The following is a description of a gene set: Genes predicted to be targets of miRBase v22 microRNA hsa-miR-4477a in miRDB v6.0 with MirTarget v4 prediction scores > 80 (high confidence targets). studied in species Homo sapiens Human Gene Set: MIR4477A from publication Chen Y, Wang X (PMID 31504780), and this is the list of marker genes: GHR, TBXAS1, MOXD1, DIP2A, TUBB3, TENT4A, KIF11, ZCWPW1, SLC4A10, SLAIN2, WASHC4, LRRC8D, LRCH2, CD274 (CD274 molecule), PPP2R2A, SLC22A15, RAP1GDS1 (NCBI Gene Id 5910), TBC1D9B, NUFIP2, ARID4A, IL2, LGALS3, MBNL3, SMAP2, PF4V1, GNGT1, PTPN4, USP47, PRICKLE1, JPH1, NR0B1, RAB21, KLHL17, SON, PASD1, TWSG1, ISL2, E2F5, LIN7C, NALF1, TMEM108, VTA1, PDE7B, CAVIN2 (caveolae associated protein 2), CTSS (NCBI Gene Id 50653), ATP8A1, FAM200C, U2AF1L4, SSR3, HMGN5, ORC6, USP25, SCAI, CNRIP1, EIF3J, SLC17A6, F2R, CNTNAP2, UBR3, NAP1L1, MKLN1, ERRFI1, PPM1E, KLHL1, UGT8, GFM1, SORBS1, MYCT1, PCOLCE2, PAGE2, RBM26, UTP18, TCEAL7, CASK, ARHGAP45, UHRF2 (NCBI Gene Id 49857), RWDD4, SLC25A24, NRXN1, ZDHHC9, ST8SIA4, KRTAP9-9, MAP4K5, RAP2C, USP43, ZCRB1, LRATD2, STIL, FZD3, OSBPL3, PTPRK, TNPO1, DNAJC25, ZDHHC13, TAF3, JAG1, KLF3, RWDD1, CLTRN, SHISA2, ENY2, MRFAP1, DLAT, SETBP1, KLF15, BLTP3B, SC5D, FBXW11, BRI3BP, C14orf132, PAMR1, MMP16, MACC1, PARG, HESX1, EYA1, ING3, MINDY2, RECK, CKAP4, GFI1, PTPRB, C5orf24, SIGLEC10, RNF213, ACKR3, ZNF280C, SLC35A4, UXS1, HOXA13, ABHD4 (NCBI Gene Id 63874), KRTAP1-5, DGKH, BRWD3, MAGEC2, RASA2, RPRM, MTHFD2, RBMX, ALDH1A1, RC3H1, UBR1, PCDHB5, KLRF1, FGFR2, RSF1, RSPO4, CACNB4, KCND2 (potassium voltage-gated channel subfamily D member 2), TENT2, SYPL1, KLHL32, IER5L, CDK15, CUX2, OXNAD1, SLC18A2, MCTS1, PTPN11, TKTL1, MPP7, ARHGEF12, TAB2, MIER3, MS4A12, TSLP, TNKS2, ACADL, TFRC, RIPOR2, GEM, GK5, TM9SF2 (transmembrane 9 superfamily member 2), UBL5, ANK1, DIPK2A, POLR2D, SDHAF3, DNAJB4, RNF138, CCP110, CEP76, HNRNPD, DHFR2, PDE11A, TPRA1, PCLO, INHBE, CDH20, CFAP95, GSPT1, ASCC3, SSPN, PKD2, AMOTL2, RNF146, SLC46A3, ENTPD1, ANAPC5, CNOT7, KLHL25, PAFAH1B1, TMEM135, GNAI1, CHRDL1, INTS12, SDE2, TRIOBP, HIGD2A, FAM120A, URGCP, LMO3, TULP4, HINT3, ARID2, SLAMF7, MAP3K2, PTAFR, NF1, TMEM129, SYCE3, SLCO1B1, KCNIP3, EED, UCN, LIMS1, PHC3, BPNT2, TGFB2, SIPA1L2, MKX, COL13A1, PAN3, RPL15, C21orf91, MAN1A1, SRPX, PPM1L, RNF13, RNF103-CHMP3, ZNF827, ICA1, ZDHHC20, NFAT5, TRPS1, GUCY1A2, ITGB4, BLZF1, SRPK3, ITFG1, FAM107B, IQCJ (NCBI Gene Id 654502), C5orf34, FOXJ2, CFAP298, MYO5A, BCAS1, CEP135, CLASP1 (NCBI Gene Id 23332), RHEB, NEDD4L, RAB27B (RAB27B, member RAS oncogene family), KBTBD2, PDXP, TMEM215, ENTR1, BNC1, TSR2, ATG3, ATP2A2, GPR176, CADM1, RP2, ASPA, FAM220A, NAE1, GDF10, YTHDF1, TNRC6C, DHFR, MLLT10, RBM41, CREBRF, NIPBL, GTF3C3, THAP2, TJP2, CARNMT1, PRDM10, BARD1, IQCJ-SCHIP1, GRM7, PSIP1, LONRF2, DCUN1D5, SMG5, UBA3, RSBN1L, MEX3C, KIF14, SASS6, C1orf43, PAGE5, NOD1, PAGE2B, ANKRD12, SPRED1, SESTD1, LSM7, LRIG3, MEX3D, IQCK, HOOK3, FAM199X, RNF145, CSHL1, NAB1, ATAD2, RALYL, LMAN1, GAS2L3, TTN, CCDC158, TSPAN7, BSPH1, SPMIP4, TOLLIP, NUDT7, DEPDC7, CRTC2, GINS1, RFLNA, MID1, CHMP3, SS18L1, IDS, DIRAS3, TFPI2, ANKRD10, SEMA4B, CDC27, CCNE1, AFDN, MYEF2, ZNF540, CCDC28A, RPRD1A, KANK2, NCBP3, ZNF431, PRLR, DGKK, NEMP1, FOXQ1 (forkhead box Q1), PLIN3, GABARAPL2, LRRC8B, RAB8B, CBX1 (NCBI Gene Id 10951), CA2, RTKN2, KRTAP3-1, ETNK1, ZNF354C, CERT1, MMUT, SPRYD7, RCOR3, HEPHL1, TMEM170B, NUP210, CLDN8, BHLHE40, STON2, TFEC, ARHGAP32, CA13, TPR, SREK1, SCEL, BRAF, TET2 (NCBI Gene Id 57667), PEX3 (NCBI Gene Id 8504), DNALI1, BMAL1, TRIL, CHD1, ZNF112 (zinc finger protein 112), PPP6C, MATN1